The following is a description of a gene set: from publication Gavish A, Tyler M, Greenwald AC, Hoefflin R, Simkin D, Tschernichovsky R, Galili Darnell N, Somech E, Barbolin C, Antman T, Kovarsky D, Barrett T, Gonzalez Castro LN, Halder D, Chanoch-Myers R, Laffy J, Mints M, Wider A, Tal R, Spitzer A, Hara T, Raitses-Gurevich M, Stossel C, Golan T, Tirosh A, Suvà ML, Puram SV, Tirosh I (PMID 37258682) studied in species Homo sapiens In this study, an extensive analysis was conducted to define meta-programs (MPs) capturing intra-tumor heterogeneity across a spectrum of tumor types. The approach utilized non-negative matrix factorization (NMF) to analyze each cell type separately within individual tumor samples. This involved the analysis of malignant cells, macrophages, fibroblasts, endothelial cells, epithelial cells, T-cells, and B-cells. NMF was executed with varying parameter values (K=4, 5, 6, 7, 8, 9), thereby generating 39 programs for each cell type per sample. Each NMF program was summarized by the top genes based on NMF coefficients.\nRobust MPs were then delineated for each cell type using a set of stringent criteria, including recurrence within the same tumor, similarity to programs in other tumors, and non-redundancy within a tumor. Subsequently, these robust NMF programs were clustered (per cell type) based on Jaccard similarity, leading to the identification of MPs associated with each cell type.\nTo enhance the quality of the MPs, a refinement steps were undertaken, involving the removal of MPs suspected of reflecting low-quality data (with an overrepresentation of ribosomal proteins or mitochondrial-encoded genes), single-study inclusion, or similarity to miss-annotated cell types. Genes upregulated in subsets of cells of a given type within various tumors Human Gene Set: GAVISH_3CA_METAPROGRAM_B_CELLS_METABOLISM_MYC, and this is the list of marker genes: ENO1, APRT, HSPD1, NDUFAB1, ERH, RAN, NHP2, PKM, PSMA4, VDAC1, PPA1, EIF5A, PA2G4, LDHA, CCT6A, PRMT1, SNRPE, TUBA1B, ABRACL, HSP90AB1, NME1 (NCBI Gene Id 7794), PSME2, TIMM13, LDHB, SYNGR2, PGAM1, PSMB3, CALR, ATP5MC1, C1QBP, TPI1, NME2, IMPDH2, TUBB, MIF, SNRPD1, HSPE1, SNRPF, EIF4A1, RPL22L1, TXN, RANBP1 (NCBI Gene Id 5902), CD83, PRELID1, FABP5, HMGA1, DDX21, PRDX1, CCT3, HNRNPAB